The following is a description of a gene set: Human Gene Set: REACTOME_INTERLEUKIN_1_SIGNALING Interleukin-1 signaling species: Homo sapiens, and this is the list of marker genes: TP53, NKIRAS1, PSMA2, NKIRAS2, SKP1, PSMA7 (NCBI Gene Id 5688), PSMD6, PSMC1, UBA52, S100B, MAP3K3, IRAK1, PSMC2, PELI2, NOD2, PSMD11, CHUK, IL1R2, MAP2K1, USP18, APP, AGER, N4BP1, PSMD13, UBE2N, MAP2K4, RBX1, NFKB1, IL1R1, PSMB5, ALPK1, IL1B, IKBKB, NOD1, CASP8, USP14, CUL1, TAB3, PSMB6, PSMB7 (proteasome 20S subunit beta 7), PSMD12, PSMD3, PSMA1 (NCBI Gene Id 5682), PSMD14, PSMC5, NFKBIB, PSMD8, TIFA, TRAF2, TOLLIP, IL1RAP, SAA1 (serum amyloid A1), PSMA3, IKBKG, IL1RN, TNIP2, NFKB2, PSMC6, PSMD2, IKBIP, TRAF6, PSMB4, PSMD7, UBB (NCBI Gene Id 91253), PSMD1, MYD88, IRAK3, IRAK2, MAP2K6, FBXW11, ADRM1, NFKBIA, PSMB2, PSMB3, NLRC5, IL1A, PSMA5, RPS27A, PELI3, NLRX1, PSMC3, SEM1, LRRC14, BTRC (beta-transducin repeat containing E3 ubiquitin protein ligase), HMGB1, RIPK2, MAP3K7, PSMC4, PELI1, TAB2, UBC, TAB1, PSMA6, IRAK4, S100A12, UBE2V1, PSMA4, MAP3K8, SQSTM1, PSMB1, RELA